The following is a description of a gene set: About 70-80% of breast cancers express estrogen receptor alpha (ER-alpha), and estrogens play important roles in the development and growth of hormone-dependent tumors. Together with lymph node metastasis, tumor size, and histological grade, ER status is considered as one of the prognostic factors in breast cancer, and an indicator for hormonal treatment. To investigate genes and pathways that are associated with ER status and epithelial cells in breast tumor, we applied laser capture microdissection (LCM) technology to capture epithelial tumor cells from 28 lymph node-negative breast tumor samples, in which 17 patients had ER-alpha+ tumors, and 11 patients have ER-alpha- tumors. Gene expression profiles were analysed on Affymetrix Hu133A GeneChip. Meanwhile, gene profiles using total RNA isolated from bulk tumors of the same 28 patients were also generated. In total, genes and genes with significant P-value and having significant differential expression between ER-alpha+ and ER-alpha- tumors were identified from the LCM data set and bulk tissue data set, respectively. A total of genes were found to be common in both data sets, while genes were unique to the LCM data set and genes were present only in the bulk tumor data set. Pathway analysis with the genes using Gene Ontology suggested that genes involved in endocytosis, ceramide generation, Ras/ERK/Ark cascade, and JAT-STAT pathways may play roles related to ER. The gene profiling with LCM-captured tumor cells provides a unique approach to study epithelial tumor cells and to gain an insight into signaling pathways associated with ER. Human Gene Set: YANG_BREAST_CANCER_ESR1_LASER_UP studied in species Homo sapiens from publication Yang F, Foekens JA, Yu J, Sieuwerts AM, Timmermans M, Klijn JG, Atkins D, Wang Y, Jiang Y (PMID 16261164) Genes up-regulated in laser microdissected (LCM) samples of early primary breast tumors expressing ESR1 vs the ESR1 negative ones., and this is the list of marker genes: CERS6, MSX2, ALAD, STK32B, RAB17, COQ7, CHMP2A, GOLGA1, GTF3C1 (NCBI Gene Id 2975), IFT46, HMGCL, DACH1, SIRT3, SNRNP35 (small nuclear ribonucleoprotein U11/U12 subunit 35), GSTZ1, MOAP1, UGCG, SIGIRR, AR, AGR2, TP53TG1, BBOF1, RAB26, PATZ1, KIAA0319L, STN1, DNAJC17, GUSBP14, IVD, CPT1A, FRAT1, EVL